The following is a description of a gene set: studied in species Mus musculus Mouse Gene Set: GOBP_AZOLE_TRANSMEMBRANE_TRANSPORT The directed movement of azoles, heterocyclic compounds found in many biologically important substances, across a lipid bilayer, across a membrane., and this is the list of marker genes: Slc38a3, Slc38a5, Slc19a2, Slc66a1, Slc25a19, Slc22a2, Slc19a3, Slc22a1, Slc25a29, Slc15a4, Slc28a1, Slc7a1, Slc47a1, Slc44a4